The following is a description of a gene set: Any process that stops, prevents or reduces the frequency, rate or extent of amyloid fibril formation. studied in species Mus musculus Mouse Gene Set: GOBP_NEGATIVE_REGULATION_OF_AMYLOID_FIBRIL_FORMATION, and this is the list of marker genes: Vbp1, Hspg2, Pfdn5, Trem2, Cryab, Pfdn6, Pfdn4, Pfdn1, Clu, Ldlr, Apoe, Pfdn2